The following is a description of a gene set: Genes up-regulated in double positive thymocytes: wildtype versus TCF3 and TCF12 knockout. We wanted to test the role of mammalian E proteins E2A and HEB in the development of T cells. Using a conditional deletion system in which these proteins are deleted at the DP stage of T cell development, we compared DP thymocytes deficient for E2A, HEB or both to wild-type thymocytes from publication D'Cruz LM, Knell J, Fujimoto JK, Goldrath AW (PMID 20154672) species: Homo sapiens Human Gene Set: GSE19923_WT_VS_HEB_AND_E2A_KO_DP_THYMOCYTE_UP, and this is the list of marker genes: BGN, NDUFB10, SSRP1, MRPS21, SFR1, COPRS, BAZ1B, CCR7, CDKN3, TAP2, CHCHD7, ENO3, LSM4, DENND5A, EXOC4, TBC1D14 (NCBI Gene Id 57533), CPT1A, ATP5IF1, FBP2, RMND1, PRR13, PHF1, NHERF1, LBR, SAE1, MAP4K4, HMGB3, PKIB (cAMP-dependent protein kinase inhibitor beta), C5orf34, RNF181, RPA3, SNAPIN, TMEM160, NDUFAF1, SLC35D1 (NCBI Gene Id 23169), HESX1, ABCB1, ITGB7, OAT, UBR7 (ubiquitin protein ligase E3 component n-recognin 7), CPT2, VAMP1, NUDT5, CRADD (NCBI Gene Id 8738), SLC16A8, CYB5A, DCTN6, NCAPH, UBE2A, SRPK2, NDST2, PRC1, RPA1, MAP2K5, DDIT4, PDE6D (phosphodiesterase 6D), PPP3CC, SUCLG2, ZMAT3, MCM5, FUCA1, TUBB, MTMR14, MSH2, DNAJC8, FKBP2, RMND5A, IMPA2, VPS28, WBP1, MRPL23, PSMB10, LAMTOR2, PSMB9, TSPAN32, DGUOK, ICAM2, GRK2, TRPV2, DCPS, ASF1A, ANAPC5, CDC6, AURKB, SEM1, LARP1, CSNK1D, MRPL35, UBXN4, SAAL1, TRAPPC1, LTB4R, AEBP2, BRCA1, MBD4, FDXR, NDUFB11, INVS, CDK2, POLE4, CCNG2, PAFAH1B3, TMOD3, PGLS, ATP5MC2, EMP3 (NCBI Gene Id 2014, epithelial membrane protein 3 (MAM blood group)), MAF1, POLA1, PDIA4, LSM14B, GALNT2, TMPO, TNP2, ACOT13, DCTPP1, OGT, CCNF, ASF1B, SAP30L, TOP2A, SWI5, ILRUN (inflammation and lipid regulator with UBA-like and NBR1-like domains), CMC2, CTSH, PLCG2, RP9, FXN, MAD2L1, ING1, PRKACB, SUN2, ASXL1, DPP7, UQCC3, MYB, TMEM106C, FABP5, COPS3, KIF20A, BTBD1, RRM1, MCM7, SUPT4H1, NELFCD, TMEM223, PNKP, PINK1, TFPI, SNX14, PCYOX1, SBNO1, MRPL51, NSMCE1, PCBD2, RALY, ANAPC2, S100A1, GPX4, RNF145, RFC2, WDR45, MTARC2, CGGBP1, RNASEH2A, USP5, BCKDK, ARL5A (ADP ribosylation factor like GTPase 5A), TCF19, CUTA, JAK1, ING4, TBCB, PSMD7, NPC1, SELENOH, CDC123, HAUS4, PGRMC1, PRDX2, P2RX4, CHORDC1, POLR1A, TRIM59, CIPC (NCBI Gene Id 85457), ABHD8, STX5, PCLAF, S100A13, ATRAID, MYL4, RTTN, TLX3, ASNSD1, TK1, CUEDC2, G6PC3, CPNE3, FAM107B, TACC3, ACYP1